The following is a description of a gene set: studied in species Homo sapiens from publication Ochiai K, Maienschein-Cline M, Simonetti G, Chen J, Rosenthal R, Brink R, Chong AS, Klein U, Dinner AR, Singh H, Sciammas R (PMID 23684984) Temporal analysis of B cell activation in vitro using CD40L and IL-2/4/5 cytokines in wild type Irf4+/+ B cells or in mutant Irf4-/- B cells harboring a tet-inducible allele of Irf4. IRF4 expression was restored, or not, in the Irf4-/- background by culturing in the presence of low or high concentrations of doxycycline. The results provide insight in the role of IRF4 expression levels in coordinating different programs of B cell differentiation. Human Gene Set: GSE46606_DAY1_VS_DAY3_CD40L_IL2_IL5_STIMULATED_BCELL_DN Genes down-regulated in CD40L and IL-2 IL-4 IL-5 stimulated at day 1 B cell wildtype versus CD40L and IL-2 IL-4 IL-5 stimulated at day 3 B cell wildtype., and this is the list of marker genes: COL15A1, BATF3, IKBKB, MAGOH-DT, ATP6V0A2, MYCBP, NUDT11, GZMB, HEG1, ZNF559, IL1A, EBF1, IL13RA1, UBE2L3, SAFB2, DDX21, TAPT1, GLRX5, CDC26, PRDM1, SMG8, TTC4 (NCBI Gene Id 7268), PTPN13, TIMM13, C1orf198, ICE1, GAL, TRIM69, AGGF1, SERPINB9, METTL1, PLD6, UBE2N, COA7, SLC16A10, EN2, METTL5, RMI1, TIFA, ADIPOR1, APPBP2 (amyloid beta precursor protein binding protein 2), COLGALT2 (collagen beta(1-O)galactosyltransferase 2), CCDC3, NOP2, PFKFB3, C14orf93, BMP2, BHLHE22, IL5, EDF1, SLC7A5, IQCG, PRKX, PHRF1, RPP30, LONRF3 (LON peptidase N-terminal domain and ring finger 3), RRS1, XPNPEP2, NOL12, VDR, NOP14 (NOP14 nucleolar protein), CAB39, ETV7, PPRC1, IL2RA, HORMAD1, KLHDC7B, BOLA3, UTP11, TGFB1, CXCL12, GATA2, PLA2G4C, RUNX1, HSD17B10, OTUD5, MVP, GID4, NPHP4 (nephrocystin 4), MALT1, HOXC10, SNRPC, ARK2N, BCL6, MTHFD2, FGFBP2, MIR155HG, ETV5, PAQR7, CSK, EFCAB14, ARPC5L, ZNRF1, RPS10P5, ERCC4, SNAPC5, TRIM22, RNF144A, NKG7, TNFAIP8, SLC12A8, CCDC32, NLRC5 (NLR family CARD domain containing 5), MDH1B, TNFRSF1B, ELP5, PTTG3P, RAB22A, RPS28, TMOD2, RPP40, SLC7A1, GPATCH4, CTPS1, TUBBP5, NOLC1, BIRC3, FASTKD2, TRERF1, CCDC117, AK4, WDR7, TXNDC16, ZMYND19, EI24, EPAS1, MED31, SCARA5, PTPRCAP, PLAT, DCAF4, FAM43A, TAL1, IFI16, PITPNA-AS1, DPM2, BATF, RRAD, LRP12, BAG2, IQCF3, FBXW2, SLC39A13, PTRH2, LINC01405, CARS1, SGK1, SNHG15, MAD2L2 (mitotic arrest deficient 2 like 2), SOCS1, APAF1, RNF213, ZNF232 (zinc finger protein 232), PIM2, STAT3, JMJD6, CLU, LINC02210, STAT1, FRMD6, KIAA0232, TBL1X, DDX6, TNFSF4, C19orf53, PUS1, MCL1, TYW5, TANC2, SLC27A2, PTGER3, PIK3CB, SNHG1, HAX1, CMC2, DUSP1, CDC123, TFRC (transferrin receptor), SATB1 (NCBI Gene Id 6304), PALB2, RNF5, AIM2, PITPNB (NCBI Gene Id 23760), PPP4R4, TARS3, FKBP5, CA4, RNF145 (NCBI Gene Id 353159), CEPT1, IL13, ARID5A, STRIP2, SCG2, DTX3L, FBXO30, NRXN2, RALB, PALD1, DNAJC6